The following is a description of a gene set: The regulated release of growth hormone from secretory granules into the blood. species: Homo sapiens Human Gene Set: GOBP_GROWTH_HORMONE_SECRETION, and this is the list of marker genes: RAB1A, CDK16, SERP1, ADCYAP1, GHRL, SELENOT, PTPN11, CHD7, ITSN1, GABBR1, GHRH (growth hormone releasing hormone), HMGA2, DRD2, GHRHR, GHSR